The following is a description of a gene set: studied in species Homo sapiens Human Gene Set: GOCC_PRONUCLEUS The nucleus of either the ovum or the spermatozoon following fertilization. Thus, in the fertilized ovum, there are two pronuclei, one originating from the ovum, the other from the spermatozoon that brought about fertilization; they approach each other, but do not fuse until just before the first cleavage, when each pronucleus loses its membrane to release its contents., and this is the list of marker genes: DPPA3, SLC2A1, CBX1, RIF1, TET3, AURKA, EED, STPG4, METTL23, CCNA2, HSF1, AKAP8, TBP, CENPF (centromere protein F), EZH2, HNRNPL, PLCZ1